The following is a description of a gene set: Nitric oxide (NO) produced by macrophages (MØs) is toxic to both host tissues and invading pathogens and its regulation is therefore essential to suppress host cytotoxicity. MØ arginase 1 (Arg1) inhibits NO production by competing with NO synthases for arginine, the common substrate of NO synthases and arginases. Two signal transduction pathways control Arg1 expression in MØs. First, a MyD88-dependent pathway induces Arg1 in intracellular infections, while a second Stat6-dependent pathway is required for Arg1 expression in alternativelyactivated MØs. We found that mycobacteria-infected MØs produce soluble factors that induce Arg1 in an autocrine-paracrine manner via Stat3. We identify these factors as IL-6, IL-10 and GCSF. We further establish that Arg1 expression is controlled by the MyD88-dependent production of IL-6, IL-10 and G-CSF rather than cell intrinsic MyD88 signaling to Arg1. Our data reveal the MyD88-dependent pathway of Arg1induction following BCG infection requires Stat3 activation and may result in the development of an immunosuppressive niche in granulomas due to the induced Arg1 production in surrounding uninfected MØs from publication Qualls JE, Neale G, Smith AM, Koo MS, DeFreitas AA, Zhang H, Kaplan G, Watowich SS, Murray PJ (PMID 20716764) Human Gene Set: GSE22935_UNSTIM_VS_48H_MBOVIS_BCG_STIM_MYD88_KO_MACROPHAGE_UP species: Homo sapiens Genes up-regulated macrophages with MYD88 knockout: untreated versus 48h after M. bovis BCG infection., and this is the list of marker genes: HGFAC, CDON, HCN2, L1TD1, USP28, OASL, MYLIP, TSNAX, SMARCA1, PHKA2, LPL, ZBED6, ZKSCAN8, PDGFB, TMEM201, HEMK1, MBD5, METTL27, ZNF287, ZNF385B, CMA1, NPR2, PPM1K, PADI1, NDUFAF2, STAB2, KCNE5, S100A1, NQO1, ANKRD26, KLHL8 (NCBI Gene Id 57563), S100B, CHST8, ATM, RPL31, PURA, CSNK1G3, BANK1, SENP7, MXRA7, RDM1, TBX21, LINS1, GPR19, CYP2F1, ARHGAP17, TSKS, SOCS1, KRT8, SPACA1, MBD4, TBC1D19, FFAR2, ZSCAN26, RAB22A, BCL7A, SNX6, WDR89, CCSAP, DGKZ, CES1, SMIM5, SERTAD4 (NCBI Gene Id 56256), PLAAT1, DBP, ANGPTL2, AAK1, RRM1, RPL37A, GAS1, MZF1, PAQR6, APOO, METTL18, ACAT1, CDC42EP3, SHC3 (SHC adaptor protein 3), UBA6, ID1, PJA2, ADAMTSL1, PLA1A, DAG1, KYAT3, PPP4R3B, TNRC6C, MBOAT1, POLR3H, TFCP2, RPL37, UQCC3, PC, EIPR1, C11orf52, GPD1, RGS2, RPP30, ADCY9, PSENEN, LGALS12, FLRT1, APPL1, ZMIZ1, NRN1L (neuritin 1 like), ZSCAN29, LRRC34, GTF3C5, LRRC39, PRDM2, CCDC51, FAM185A, PDS5A, ZKSCAN8P1, BTLA, FAM178B, FBXO31, USP36, NUDT16L1 (NCBI Gene Id 84309), CDRT4, ANP32A, KDM5B, DNAAF10, ANKH, ZFP2, ALDOB, POMC, CDO1, GPIHBP1, NELFA, TXNIP, TRAF5, RGS18, MTF2, PIGO, PIK3IP1, PHF20L1, PIWIL4, FYTTD1, ZFP82 (ZFP82 zinc finger protein), DIXDC1, LEPR, ZKSCAN3, REM1 (NCBI Gene Id 28954), SNRNP48, GSTM4, IMPDH2, PEG3, CBFA2T3, PXMP2, ZNF622, GCFC2, MTARC1 (mitochondrial amidoxime reducing component 1), DUSP19, ADIG, PRORP, SOX5, CYP4B1, OBI1, SENP8, HUNK, METTL23, FCER2, GID4, FMO1, PSTK, ZNF526, DBNDD2, HTRA4, TAF3, TF, LRRC24, YIPF7 (NCBI Gene Id 285525), RPL10, DNAJB13, CELF4, FILIP1, TDRKH, RGS3, JCHAIN, APOM, HEXD, INCA1 (NCBI Gene Id 388324), KLHL28, CAMK2N1, SYNRG, LYPD6 (NCBI Gene Id 130574), CFD, KAZALD1, SCRG1, CSPG4, MDH1, PSMC3IP, MRTFB, PEX11A, MSX2, TSPAN12, PLEKHH3, POT1, BEND7, PPARG